The following is a description of a gene set: ROBO4 and VEGF signaling crosstalk species: Homo sapiens Human Gene Set: WP_ROBO4_AND_VEGF_SIGNALING_CROSSTALK, and this is the list of marker genes: SRC, ROBO4, VEGFA, SLIT2, KDR, RAC1